The following is a description of a gene set: species: Homo sapiens from publication Chen Y, Wang X (PMID 31504780) Genes predicted to be targets of miRBase v22 microRNA hsa-miR-3622a-5p in miRDB v6.0 with MirTarget v4 prediction scores > 80 (high confidence targets). Human Gene Set: MIR3622A_5P, and this is the list of marker genes: DUSP9, MTUS2, NR4A2, SP1, HIC1, CDCA7L, FUT8, SEC24D, HADHB, PLAG1, SLC38A2, TRIM66, TMEM117, MTMR10, GAREM1, CDK19, ATAD2B, PDGFC, GATA6, LUC7L2, SMCO1, SEC11A, PHKA1, GLCE, ATRN, ATP6V0E1, LIFR (LIF receptor subunit alpha), FMC1-LUC7L2, SOCS5, ACAN, E2F3, CCND2, FSD1L, FCHSD2, ALG13, ANKRD50, NNT, PRRX1, PTBP2, AMOT, TNS1, SP7, STK26, VAT1L